The following is a description of a gene set: Any process that stops, prevents or reduces the frequency, rate or extent of lens fiber cell differentiation. Human Gene Set: GOBP_NEGATIVE_REGULATION_OF_LENS_FIBER_CELL_DIFFERENTIATION species: Homo sapiens, and this is the list of marker genes: FOXE3, SPRED1, SPRED3, SPRY1, SPRED2, SPRY2